Given this list of marker genes ABCC8, SNX4, CPT1A, STX4, TNF, ITSN1, HLA-DRB1, RFX6 (NCBI Gene Id 222546), PPP3CB (protein phosphatase 3 catalytic subunit beta), SOX4, VAMP7, IFNG, CELA2A, GALR1 (NCBI Gene Id 2587), GCG, BAD, TACR1, G6PC2, GIPR, PRKAR1A, PFKM, TARDBP, KLF7, ZBED6, PDE8B, CCKAR, IRS2, NOS2, FFAR4 (NCBI Gene Id 353126), GLUD1, RAPGEF4, KCNJ11, FOXL2, FKBP1B, TFAP2B, MPC2, NPVF, ENSA, IRS1, LRP5, ANO1, BRSK2, FGB, INS, INHBA, ADORA1, NDUFAF2, GCK, HCAR2, PPARD, CHD7, VAMP3, PLA2G3, EIPR1, PICK1, SNX6, GIP, PIM3, KCNA5, SPP1, UQCC2, CRH, HIF1A, PER2, PRKCE, UCN3, RETN, TFR2, NMU, RAC1, ACVR1C, GNAO1, SSTR5, SELENOT, SIRT3, NEUROD1, AGT, GJA1 (NCBI Gene Id 7953), POMC, C2CD2L, AIMP1 (aminoacyl tRNA synthetase complex interacting multifunctional protein 1), F2RL2, TRPM4, TMF1, PFKFB2, NNAT, OXCT1, IL1B, F2, INHA, LRRC8A, CASR, MLXIPL, KDM5B, FOXO1, GNA11, FGFR1, ITPR1, BAIAP3, SLC8B1, FGF23, UCN, TAC1, SOX11, RAB11FIP3, PASK, TUNAR, FOXA2, CRHR1, CCN3 (NCBI Gene Id 4856), FFAR2, OPRK1, CHRM3, PLCB1, ILDR1, SLC9B2, HMGA2, CFTR (NCBI Gene Id 1080), CCL5, SLC30A8, CRY2, CREB1 (cAMP responsive element binding protein 1), APLN, PAX8, SLC25A22, ANXA1, GPLD1, KCNK16, HNF4A, ADIPOQ, BMP8A, KCNB1, RBP4, OSM, OSBP, ORAI1, EDN1, F2RL1 (NCBI Gene Id 7901), SIDT2, JAGN1, ADCY5, SIRT4, HTR1A, NKX6-1, SLC16A1, SYT7, CAPN10, BMP6, RAB11FIP1 (RAB11 family interacting protein 1), RASL10B, PDX1, ADCY8, HTR2C, ABCA12, TCF7L2, ALOX5, ACSL4, SLC2A2, FGG, EDN3, GPRC6A, SERP1, GNAI1, NMB, GPR68, VAMP8, NADK, MYRIP, TACR2, ADRA2C, PTPN11, NR0B2, GNAZ (G protein subunit alpha z), RAB11FIP5, GRP, NR1H4, UCP2, CDK16, PLA2G6, REN, CLOCK, MTNR1B, AACS, PPARG, FFAR1, P2RY1, SIRT6, CRY1, IL11, SNAP25, TRPA1, TRH, CHGA, DAB2, RPH3AL, SREBF1, CRHBP, GHSR, NR1D1, RFX3, C1QTNF1, FGA, GABBR1 (gamma-aminobutyric acid type B receptor subunit 1), PRKCB, DRD2, C1QTNF12, TSPO, IL6, ISL1, GHRHR, TNFSF11, NLGN2, NKX3-1, REST, PSMD9, STXBP4, INHBB, TM7SF3, BMAL1, PRKD1, EFNA5, SCG5, PHPT1, JAK2, EPHA5, GAL, SYBU, STX1A, ABAT, LEP (NCBI Gene Id 3952), MCU, DOC2B, GPR27, PRKACA, ADCYAP1, ENY2, NPFF, FAM3D, TCIRG1, GHRL, VAMP2, CD38, ADRA2A, HADH, PCK2, RAPGEF3, HFE, GPER1, DYNLL1, LIF, AGTR1, GHRH, SYTL4, CYP19A1, RAB8B, FFAR3, PFKL, PRKN (NCBI Gene Id 8004), C1QTNF3, SMAD4, GDF9, TRPM5, SCT, PRKCA, MYB, CARTPT, SRI, KCNK9, GNAS, MIDN, BLK, VSNL1, ECRG4, here is a description of the gene set: studied in species Homo sapiens Any process that modulates the frequency, rate or extent of the regulated release of a hormone from a cell. Human Gene Set: GOBP_REGULATION_OF_HORMONE_SECRETION